The following is a description of a gene set: studied in species Mus musculus Binding to a component or product of the complement cascade. Mouse Gene Set: GOMF_COMPLEMENT_BINDING, and this is the list of marker genes: Cd93, Masp2, Itgam, Crp, Serping1, Megf10, Cd59b (CD59b antigen), Itgb2, Cfhr1, Apcs, C4a, Mptx2, C5ar1, Ptx3, Mptx1, Cr2, C4b, C3ar1, Phb1, Vsig4, Cr1l, C1qbp, Cd59a, C8a, Cfhr2, Cfhr4, Cfh, C8g, Calr